The following is a description of a gene set: Any process that activates or increases the frequency, rate or extent of cell-cell adhesion mediated by cadherin. Human Gene Set: GOBP_POSITIVE_REGULATION_OF_CELL_CELL_ADHESION_MEDIATED_BY_CADHERIN species: Homo sapiens, and this is the list of marker genes: WNT3A, DENND6A, ADAM19, PTPRU, SMAD7, WNT5A, FLOT1 (flotillin 1), TJP1, FOXA1, SERPINF2, FOXA2, AFDN